Given this list of marker genes Pcsk1, Fgf10, Syt1, Npy2r (NCBI Gene Id 18167), Lin28b, Sacs (NCBI Gene Id 50720), Pcdh20, Mdh1b, Cntnap1, Frmd4a, Cacnb3, Ptprr, Nol4, Robo2, Extl1 (NCBI Gene Id 56219), Sox6, Lrrtm3, Serpini1, Sptssb, Npy1r, Rnf207, Meis1, Kcnj2, Mchr1, Pth2r, Zfp459 (zinc finger protein 459), Adm2, Ypel4, Opcml, Ido1, Coro1a, Kcna4, Tal2, Tmem100, Nol3, Caly, Usp44, Pak5, Klhl1, here is a description of the gene set: Mouse Gene Set: MIKKELSEN_MEF_ICP_WITH_H3K4ME3_AND_H3K27ME3 from publication Mikkelsen TS, Hanna J, Zhang X, Ku M, Wernig M, Schorderet P, Bernstein BE, Jaenisch R, Lander ES, Meissner A (PMID 18509334) species: Mus musculus Genes with intermediate-CpG-density promoters (ICP) bearing the bivalent tri-methylation marks at H3K4 (H3K4me3) and H3K27 (H3K27me3) in MEF cells (embryonic fibroblasts). Somatic cells can be reprogrammed to a pluripotent state through the ectopic expression of defined transcription factors. Understanding the mechanism and kinetics of this transformation may shed light on the nature of developmental potency and suggest strategies with improved efficiency or safety. Here we report an integrative genomic analysis of reprogramming of mouse fibroblasts and B lymphocytes. Lineage-committed cells show a complex response to the ectopic expression involving induction of genes downstream of individual reprogramming factors. Fully reprogrammed cells show gene expression and epigenetic states that are highly similar to embryonic stem cells. In contrast, stable partially reprogrammed cell lines show reactivation of a distinctive subset of stem-cell-related genes, incomplete repression of lineage-specifying transcription factors, and DNA hypermethylation at pluripotency-related loci. These observations suggest that some cells may become trapped in partially reprogrammed states owing to incomplete repression of transcription factors, and that DNA de-methylation is an inefficient step in the transition to pluripotency. We demonstrate that RNA inhibition of transcription factors can facilitate reprogramming, and that treatment with DNA methyltransferase inhibitors can improve the overall efficiency of the reprogramming process.